The following is a description of a gene set: Genes up-regulated in comparison of naive CD4 T cells versus stimulated CD4 Th2 cells at 48 h. Immune cell-specific expression is one indication of the importance of a gene's role in the immune response. In order to identify such patterns, we set out to broadly profile gene expression in a variety of immune cells. Human Gene Set: GSE22886_NAIVE_CD4_TCELL_VS_48H_ACT_TH2_UP from publication Abbas AR, Baldwin D, Ma Y, Ouyang W, Gurney A, Martin F, Fong S, van Lookeren Campagne M, Godowski P, Williams PM, Chan AC, Clark HF (PMID 15789058) species: Homo sapiens, and this is the list of marker genes: RXRA, SMPD1, ANKRD28, USP19, PRKG2, LZTFL1, TBXA2R, MYLIP, LY75, ZFPL1, MYOZ3, RETREG1, LARS1, FAAH, MSL3, PTGER1, TSPAN32, RIPOR2, IPCEF1, TNFRSF25 (TNF receptor superfamily member 25), PHKA2, CBX4, UBP1, SLC2A4RG, RPL36A, FAM83E, NOSIP, VILL, KAT8, NUMA1, SPINK2, LIPT1, MYO15B, RASGRP2, STAT5B, LITAF, TRIM3, THBD, RPL10A, SNHG17, CLUHP3 (NCBI Gene Id 79014), CSGALNACT1, INKA2, OSER1, RBM38, HKDC1, ACTN1, EAPP, VIPR1, RAPGEFL1, C11orf21, UXS1, COQ8A, PCIF1, RERE, IFI44, ELF2, GLS2, TMEM131L, SLC25A36, ISLR (immunoglobulin superfamily containing leucine rich repeat), FCGRT, RYK, PXN, P3H4, PGAP3, BEX4, NEURL1, MPO, DUSP1, PRB3, RPL30, MAPT, ANKRD6, DLG1, ZNF692, C1QA, ZNF609, FAU, PLEC (NCBI Gene Id 5339), BCL2, ETV3, SYT17, PTP4A3, DHRS3, LILRB3, ZBTB25, FOXL1, BBOF1, IDUA, RPL3 (NCBI Gene Id 6122), KCTD12, SF3A1, B4GALT7, ADD3, ZNF91, XKR8, HOOK1, C1orf115, SAMHD1 (SAM and HD domain containing deoxynucleoside triphosphate triphosphohydrolase 1), SCARB2, TMEM30B, PARP6, CUTA, RPL17, PEX16, TRAM2, BAG3, ELANE, KAT2A (NCBI Gene Id 2648), TTC3, CDC42BPB, DDAH1, C2, CPVL, CLASRP, EIF3D, ZCCHC14 (zinc finger CCHC-type containing 14), GJA5, TCEAL4, PRKCZ, ITPKB, RNF114, MYC, SLC25A37, UFM1, DVL2, LSR, PPFIBP2, RREB1, RPL29, CIRBP, NDST1, ZXDC, VPS9D1, LTBP3, CMPK1, TRIM44, MFNG, CHRNB2, GJB3, PLAC8, TRMT61A, TSC22D3, CRY2, PDE8A, ACBD4, PABPC1, SMAGP, RPL21, CLCN2, RPL8, ARFGAP2, ISG20, GRINA, EDN1, MYH3, LEPROTL1, RPLP2, ZNF394, RPS28, CD248, TRIB2, XPO6, HIC2, FAM110D, NCK2, SNN, KLF9, ZNF318, DBP, SARAF, SLC48A1, ZBTB18, LYRM9, SARDH, ALDH2 (aldehyde dehydrogenase 2 family member), CXCR4, EEF2, FAM163A, A4GALT, RPS10P5, WSCD2, PLXDC1, CHD7, RPS6, CTNNA2, SUN1, RSAD1, DVL1, ECE1, ENTPD6, PRMT2, RPS9, TRPS1, RPL32, AHDC1, TNS2, DHRS12, COPG2IT1